Given this list of marker genes BBS4, ELP1, PTPN22, TSPAN13, STAT4, HNRNPF, ASXL2, MAPK9, GART, YTHDC2, ANAPC13, CWC25, CREM, RSAD2, PTK2, URI1, MKLN1, RPS14, ATP13A5, SYNE1, EML5, DDHD1, CALCOCO2, HHLA1, ARMC1, PARP8 (NCBI Gene Id 79668), ATAD5, IRF7, PRPF38A, WDR11, TAF9B, RTP4, UTP25, ERLIN1, DESI2, COASY, CDR2, HELZ2, NUDT22, IL18R1, TSPYL2, TMEM86B, ZSWIM1, SEC23IP, RAD18, ABCA5, MRPL15, IFFO1, CYLD, ZBTB20, KEL, CUL4A, CXCL13, CARF, NELFE, CD200, ISOC1, SUCLG2, ARL6IP4, CRCP, SDC2 (syndecan 2), DPPA3, PCBP1, TOR3A, THBD, MTDH, FBXL20, N4BP2L1, E4F1, P3H1, LSG1, INPP5F, TMEM167A, POLR2C, DUSP22, GPHN, GPCPD1, ZC3H6 (zinc finger CCCH-type containing 6), MRPL50, TASP1, SLC11A2, COPS2, FAM168A, APTX, CCIN, TRMT11, ABT1, UST, ECI2, ISYNA1, AP3S1, DDX56, ATE1, ARHGAP18, GDA, MIR488, DNMT1, WDR53, GABRG1, DARS2, HIPK1, FECH (NCBI Gene Id 2235), VPS16, TFRC, LRIG3, TAF5, XRN1, VPS50, SMAD2, CENPH, LRRFIP2, RPL32, FBXO38, PDE4A, WASL, RBKS, PPFIA2, CHRM5, KLHL18, MED16, COQ6, GGCX, FLVCR1, ANKRD52, CLCC1, SPACA1, FKBP11, TUBGCP2, PTPN11, DDX6, AARSD1, NRN1, ANAPC1, HERC3, DDHD2, ACVR2A, SNAPC4, EXOC1, PIGK, RPL23, CASP4, USP16, GALC, CHD9, UBR1, KLF12, AOC2, TRIM58, NENF, CHCHD3, CARD11, PHTF2 (putative homeodomain transcription factor 2), APOBEC1, SGF29, here is a description of the gene set: from publication Zhou X, Jeker LT, Fife BT, Zhu S, Anderson MS, McManus MT, Bluestone JA (PMID 18725525) Human Gene Set: GSE11818_WT_VS_DICER_KO_TREG_DN studied in species Homo sapiens Genes down-regulated in T reg: wildtype versus DICER1 knockout. A new Treg-specific, FoxP3-GFP-hCre BAC transgenic was crossed to a conditional Dicer knock-out mouse strain to analyze the role of microRNAs (miRNA) in the development and function of regulatory T cells (Tregs). Although thymic Tregs developed normally in this setting, the cells showed evidence of altered differentiation and dysfunction in the periphery. Dicer-deficient Treg lineage cells failed to remain stable as a subset of cells down-regulated the Treg-specific transcription factor, FoxP3, while the majority expressed altered levels of multiple genes and proteins (including Neuropilin 1, GITR and CTLA-4) associated with the Treg fingerprint. In fact, a significant percentage of the Treg lineage cells took on a Th memory phenotype including increased levels of CD127, IL-4, and interferon-g. Importantly, Dicer-deficient Tregs lost suppression activity in vivo; the mice rapidly developed fatal systemic autoimmune disease resembling the FoxP3 knockout phenotype. These results support a central role for miRNAs in maintaining the stability of differentiated Treg function in vivo and homeostasis of the adaptive immune system.